The following is a description of a gene set: Human Gene Set: REACTOME_CELL_SURFACE_INTERACTIONS_AT_THE_VASCULAR_WALL Cell surface interactions at the vascular wall studied in species Homo sapiens, and this is the list of marker genes: GPC1, TNFRSF10A, PLCG1, IGKV1-12, PIK3R1, IGKV2D-30, IGLC3, IGKV1D-33, FCER1G, TNFRSF10D (TNF receptor superfamily member 10d), MIF, IGHV4-39, FN1, IGKV5-2, L1CAM, ITGA6, ESAM, IGHV3-13, OLR1, TNFRSF10B, PICK1, IGLV6-57, ITGB2, IGHA2, IGLV2-11, IGHV2-5, PSG8, TGFB1, IGKV2-28, SIRPG, SLC16A1, IGHV3-48, PSG9, ATP1B3, IGHV4-34, PSG1, CD177, CXADR, CAV1 (NCBI Gene Id 857), IGLV3-19, SOS1, ITGA4, ITGB3, IGHV1-2, IGLV2-23, CD74, PF4V1, ITGAV, KRAS, IGKV1D-12, CD2, MERTK, SLC7A10, JAM2, ITGAL, TREM1, PIK3CB, IGKV3-11, IGLV1-40, IGLV3-1, SLC7A9, CD99, PSG4, ANGPT2, PSG11, SLC7A8, TEK, CD47, CD244, IGLV3-27, PECAM1, LYN, IGHV1-46, SELPLG, SLC7A6, CEACAM5, GRB7, SLC7A7, GYPC, PROS1, PSG6, IGKV3D-20, INPP5D, IGLV7-43, VPREB1 (V-set pre-B cell surrogate light chain 1), IGHV3-11, GP6, PIK3CA, ITGA5, SLC16A8, PTPN11, IGKV2-30, SPN, IGLV3-21, CEACAM3, SIRPA, PSG5, GLG1, PTPN6, MAG, IGKV1D-16, JAML, IGKV4-1, CD58, PSG3, ITGAM, IGHV2-70, IGKV1D-39, IGHV1-69, ITGA3, ITGB1, IGLV3-25, SLC7A11, IGHV3-33, IGLC2, SLC3A2, SDC3, JCHAIN, PSG7, APOB, SDC4, CEACAM8, IGLV2-14, ITGAX, ATP1B2, NRAS, IGKV1-17, IGKV1-5, F2, COL1A1, ANGPT4, PROCR, PPIL2 (peptidylprolyl isomerase like 2), SELL, THBD, PIK3R2, IGKV1-33, COL1A2, SDC1, IGKV2D-40, GRB14 (NCBI Gene Id 2888), CD44, GYPB, IGKV1-39, JAM3 (junctional adhesion molecule 3), IGKV3-20, SHC1, MMP1, SLC16A3, FYN, IGHV3-23, VPREB3, CEACAM6, CD99L2, IGLV1-47, CD48, EPCAM, GAS6, PSG2, YES1, IGHM, SELP, IGLV2-8, IGHA1, GRB2, ATP1B1, GYPA, IGHV3-53, PROC, BSG, CD84, IGKV1-16, PPIA (NCBI Gene Id 5478), IGLV1-44, LCK, PF4, F11R, TSPAN7, SRC, IGHV3-7, CEACAM1, ANGPT1, SLC7A5, IGHV4-59, DOK2, IGHV3-30, SDC2, FCAMR, IGLV1-51, HRAS, IGKV2D-28, IGKV3-15, IGLL1, SELE